The following is a description of a gene set: Mouse Gene Set: GOBP_STEM_CELL_DEVELOPMENT The process whose specific outcome is the progression of the stem cell over time, from its formation to the mature structure. Cell development does not include the steps involved in committing a cell to its specific fate. species: Mus musculus, and this is the list of marker genes: Arb2a, Pdcd6, Nrp1, Pef1 (penta-EF hand domain containing 1), Phox2b, Sema6c, Sox9, Bmp7, Folr1, Sema3d, Hand2, Sema4b, Foxc2, Alx1, Aldh1a2, Ankrd11, Kbtbd8, Tapt1, Sema4a, Sema4g, Fn1, Cdh2, Sema4c, Sema4d, Erbb4, Pax3, Sema5a, Sema6b, Ednra, Lama5, Nrtn, Nrp2, Foxc1, Shh, Tbx1, Sema6d, Twist1, Ovol2, Hes1, Hif1a, Cdc42, Sema3e, Bcl2, Sox8, Radil, Rdh10, Ednrb, Eng, Snai2, Mir452, Mapk1, Cfl1, Smo, Edn3, Pitx2, Tfap2a, Bmpr1a, Efnb1, Htr2b, Sema3g, Mir7-2, Fgf2, Setd2, Sema5b, Ret, Sox10, Mir7-1, Bmp4, Cyp26c1, Dicer1, Gbx2, Sema7a, Klhl12, Edn1, Isl1, Pax6, Nolc1, Cited2 (Cbp/p300-interacting transactivator, with Glu/Asp-rich carboxy-terminal domain, 2), Gdnf, Fgf15, Sema6a, Coro1c, Sema3a, Tcof1, Sema4f, Mir203, Mapk3, Zeb2, Phactr4, Kitl, Wnt7b, Msi2, Jag1, Cyp26a1, Acvr1, Sema3f, Sema3c, Ptprc, Wnt7a, Sema3b